The following is a description of a gene set: Any process that results in a change in state or activity of a cell or an organism (in terms of movement, secretion, enzyme production, gene expression, etc.) as a result of an alkaloid stimulus. Alkaloids are a large group of nitrogenous substances found in naturally in plants, many of which have extracts that are pharmacologically active. species: Mus musculus Mouse Gene Set: GOBP_RESPONSE_TO_ALKALOID, and this is the list of marker genes: Ryr2, Grin1, Homer2, Elavl4 (ELAV like RNA binding protein 4), Cnr1, Ppp1r9b, Cdk5, Pdx1, Drd4, Gprin3 (GPRIN family member 3), Ryr1, Ppp5c, Mecp2, Prss2, Gria1, Cacng4, Abcb1a, Hnmt, Crhr1, Ppp1r1b, Irs1, Grm2, Srsf9, Ppp2r2a, Drd5 (NCBI Gene Id 13492, dopamine receptor D5), Ehmt2, Sox17, Uqcrc1 (ubiquinol-cytochrome c reductase core protein 1), Casp6, Casq2, Recql5 (RecQ protein-like 5), Mdm2, Htr2a, Bche, Adora2a, Myrf, Crebbp (CREB binding protein), Setd2, Cartpt, Oprk1, Dnmt3a, Htr1b, Tmem38b, Crhbp, Slc6a3, Selenon, Blm (Bloom syndrome, RecQ like helicase), Drd2, Oprm1, Slc6a4 (NCBI Gene Id 216958), Hdac5, Ccna2, Tgm2 (transglutaminase 2, C polypeptide), Smpd1, Comt, Cad, Oxtr, Slc8a1, Drd1, Pitx3, Spidr, Dlg4, Tmem38a, Adra2a, Drd3, Arc, Myc, Casp3 (NCBI Gene Id 12367), Npy1r, Ryr3, Adra1b, Gnal, Fkbp5, Nos1, Sdk1, Prkaa1, Pgr, Snca, Trpv1, Chrnb2, Crh, Prkce, Fancb, Th, Tacr3, Xlr4a, Adgrl3, Ncam1, Ube3a, Fkbp1a, Pdcd4 (programmed cell death 4), Star, Hsp90aa1, Slc1a3, Slc1a1, Homer1, Fadd, mt-Nd6, Gad2, Cpt1a, Oxt, Prkaa2, Cacna1s, Bdnf, Adcy8, Bcl2l1, Gstm7 (glutathione S-transferase, mu 7), Dhx15, Mtor, Nqo1, En1, Parp1, Ptk2b, Casp7, Abat, Prkcg, Fosb, Hes1 (NCBI Gene Id 15205), Rad51, St8sia2, Chek1, Slc1a2 (solute carrier family 1 (glial high affinity glutamate transporter), member 2), Xlr4b